The following is a description of a gene set: Human Gene Set: GOBP_ATP_SYNTHESIS_COUPLED_ELECTRON_TRANSPORT studied in species Homo sapiens The transfer of electrons through a series of electron donors and acceptors, generating energy that is ultimately used for synthesis of ATP., and this is the list of marker genes: UQCRQ, NDUFA9, NDUFS6, COX6A2, SDHD, COX7A2, BID, DGUOK, MT-ND5, UQCRB, DLD, NDUFC1, SDHA, UQCR10, SDHAF2, COA6, NDUFA5, UQCR11, COX5B, COQ9, NDUFB10, COX4I1, MT-CO1, MT-ND3, NDUFA12, UQCRC1, NDUFB4, NDUFV1, COX6C (cytochrome c oxidase subunit 6C, NCBI Gene Id 1345), SDHB, UQCRFS1P1, MIR210, MT-ND4, MT-ND1, NDUFB3, CYCS, NDUFB7, UQCC3, NDUFA8, DNAJC15, PARK7, NDUFAB1, UQCRFS1, NDUFB6, COX6A1, NDUFAF1, NDUFS2, PINK1, MT-ND4L, NDUFB9, ISCU, NDUFB8, NDUFS4, NDUFS1, NDUFA7, NDUFA3, NDUFV2, MT-ND2, NDUFB1, NDUFA6 (NADH:ubiquinone oxidoreductase subunit A6), MTCO2P12, CCNB1 (cyclin B1), UQCRHL, CYC1, COX7A1, SNCA, MTCH2, COX7C, NDUFA1, UQCRC2, MT-CO2, NDUFS7, COX7B, NDUFV3, SDHC, NDUFS3, NDUFA11, COX7B2, NDUFS5, NDUFC2-KCTD14, NDUFA10, MT-CO3, COX7A2L, MT-CYB, COX8A, NDUFS8 (NCBI Gene Id 4728), COX4I2, GHITM, CHCHD2 (NCBI Gene Id 92547), CDK1, NDUFB2, COX5A, NDUFA2, COX7A2P2, NDUFB5, NDUFC2, UQCRH, COX8C, NDUFA4, COX6B1, MT-ND6